Given this list of marker genes PDGFB, GRM6, TRPV2, CCL3, STRIT1, AKAP5, P2RX1, PPP3R1, P2RX5, PPP3CA, CASR, STC1, PPP3R2, ATP2C2 (ATPase secretory pathway Ca2+ transporting 2), CRH, ISL1, CXCL12, PDGFRB, LGALS3, UCN, CASK, PPP3CB, GCG, TRPV3, MS4A1, PPP3CC, CCL2, here is a description of the gene set: Any process that increases the rate, frequency, or extent of the directed movement of calcium ions into a cell or organelle. studied in species Homo sapiens Human Gene Set: GOBP_POSITIVE_REGULATION_OF_CALCIUM_ION_IMPORT